Given this list of marker genes Vstm2a, Cidea, Rbp1, Cpt1a, Tmem135, Pnpla2, Clstn3, Ces1c, Srebf1, Nr1h3, Mup4, Acvr1c, Scarb1, Cry1, Fitm1, Acacb, Mup1, Lep, Fxn, Soat1, Plin2, Apoe, Fitm2, Sqle (NCBI Gene Id 20775, squalene epoxidase), Negr1, Rnf213, Ffar2, Cry2, Mospd2, Itgb3, Lpl, Pla2g10, Ptpn2, Ppara, Cidec, Soat2, Apoc4, Cd36, Angptl3, Plin3, Abcg1, Hexb, Gla, Crp, Apoa1, Apob, Alkbh7, Tnf, Ces1a, Asxl1, Mup5, Ehd1, Fto, Srebf2, B4galnt1 (NCBI Gene Id 71257), Enpp1, Cds2, Ces1d, Itgav, Aup1 (ancient ubiquitous protein 1), Msr1, Mup2, Ces1h, Stat5a, Zfyve1 (NCBI Gene Id 217695), Cds1, Pparg, Lrat, Ces1b, Plin5, Hilpda, Il1b, Osbpl11, Ldaf1, Ppard, Mup3, Ces1e, Stat5b, Trem2, Zc3h12a, Asxl2, Gba1, Bscl2, Cav1, C3, Bltp1, Ces1g, Pisd, Abhd5, Nr1h2, Sirt1, Osbpl8, Ldah, Dgat1, Npc2, Pla2g4c, Nfkbia, Lipa, Stard4, Smim22, Mup11, Hexa, Gm2a, Ces1f, Ikbke, Nfkb1, Npc1, Dgat2, Nrip1, Ttc39d, Cideb, Ttc39b, Mest, Dysf, here is a description of the gene set: Mouse Gene Set: GOBP_NUTRIENT_STORAGE The accumulation and maintenance in cells or tissues of a nutrient, a substance that is used by an organism to survive, to grow, and to reproduce; such as proteins, vitamins, and minerals. Nutrient reserves can be accumulated for mobilization and utilization when needed. species: Mus musculus